The following is a description of a gene set: studied in species Mus musculus Mouse Gene Set: GOCC_CELL_DIVISION_SITE The eventual plane of cell division (also known as cell cleavage or cytokinesis) in a dividing cell. In Eukaryotes, the cleavage apparatus, composed of septin structures and the actomyosin contractile ring, forms along this plane, and the mitotic, or meiotic, spindle is aligned perpendicular to the division plane. In bacteria, the cell division site is generally located at mid-cell and is the site at which the cytoskeletal structure, the Z-ring, assembles., and this is the list of marker genes: Cep55, Diaph3, Maea, Lima1, Rhoa, Rab11a (NCBI Gene Id 53869), Zfyve19, Plekhg6, Rhob, Stambp, Rdx, Ect2, Myh2, Cit, Mylk, Kif20a, Or2a7 (olfactory receptor family 2 subfamily A member 7), Ssh1, Septin2, Spire2, Ankrd45, Myh9, Rab11fip3, Anln, Septin1, Men1, Plk4, Septin6, Septin4, Septin12, Nde1, Septin10, Spn, 4930544G11Rik, Hmcn2, Septin9, Septin14, Septin5, Htr3a, Fsd1, Katnbl1, Svil, Plcd3, Rala, Myh10, Hmcn1, Septin8 (septin 8), Psd3, Pstpip1, Rtkn, Psd, Spire1, Pkn2, Dctn3, Nf2 (neurofibromin 2), Wdr73, Racgap1, Mastl, Pkn1 (protein kinase N1), Arf6 (ADP-ribosylation factor 6), Rhoc, Septin3, Septin11, Ppp1cc, Septin7 (NCBI Gene Id 235072), Icam2, Pitpnm1, Gtf2b, Psd2, Rab11fip4, Tpm3, Pdxp, Rab21